The following is a description of a gene set: An anomaly of the white matter of brainstem. Abnormal brainstem white matter morphology studied in species Homo sapiens Human Gene Set: HP_ABNORMAL_BRAINSTEM_WHITE_MATTER_MORPHOLOGY, and this is the list of marker genes: FLI1 (Fli-1 proto-oncogene, ETS transcription factor), SACS, CSPP1, CLCN3, ABCD1, LMNB1, NPHP1, INPP5E, CEP290, AHI1, LAMA1, ARL3, CYP27A1, TMEM67, KIAA0586 (NCBI Gene Id 9786), TMEM216